Given this list of marker genes POLR2G, DAZL, EIF2AK4, RPS6KB1, MTOR, NCK1, PPP1R15A, YTHDF1, CCL5, DAZ2, DHX29, HABP4 (NCBI Gene Id 22927), AKT2, DNAJC3, UHMK1, METTL3, RPS6KB2, LARP1, SH3BGRL, DAZ3, EIF2B5, YTHDF2, BOLL, PKP1, DAZ4, YTHDF3, TNF, DAZ1, DDX3X, KHDRBS1, here is a description of the gene set: Any process that activates or increases the frequency, rate or extent of translational initiation. studied in species Homo sapiens Human Gene Set: GOBP_POSITIVE_REGULATION_OF_TRANSLATIONAL_INITIATION